Given this list of marker genes IMPACT, NAP1L2, FOXA1, GDF6, NRCAM, MIR146A, CPNE1, DUOXA1, FOXG1, BNIP2, GDF5, BRINP1, IRX3, GPRC5B, FEZF1, CYB5D2, HMG20B, REST, MICOS10-NBL1, UPF3B, SOCS2, NKX2-2, RNF112, TRIM32, MEF2C, SIN3A, MMD, SH3GL3, DMD, NEUROG1 (neurogenin 1), CXCL12, NCOA1, NEUROD1, HEYL, VWC2, DAB1, RHOA, ARHGEF2, NKX2-5, TCF12, BMP4, NKX6-1, RARA, FEZF2, TGIF2, BMP2, DKK1, S100B, BCL6, DLX1, MIR511, BMP7, FGFR1, ADRA2C, GDF7, BRINP2, NEUROG3, TRPC6, BMP6, TRPC5, MAP1B, PROX1, ECT2, HOXD3, ZEB1, ETV5, NGF, DLX2, SPAG9, EIF4G1, PHOX2B, BRINP3, VWC2L, NBL1, EPO, SHOC2, CDON (NCBI Gene Id 50937), ASCL1, ZC4H2, KCTD11, GDPD5, TCF3 (NCBI Gene Id 6929), APP, LIN28A, PCP4, TCF4, ADRA2B, GATA2, ATOH1, NEUROD2, MMD2, BEND6, SOX11, FGF2, TGIF1, MIR137, FGF20, here is a description of the gene set: Human Gene Set: GOBP_POSITIVE_REGULATION_OF_NEURON_DIFFERENTIATION Any process that activates or increases the frequency, rate or extent of neuron differentiation. studied in species Homo sapiens